The following is a description of a gene set: Mouse Gene Set: GOBP_REGULATION_OF_CALCIUM_ION_IMPORT Any process that modulates the rate, frequency, or extent of the directed movement of calcium ions into a cell or organelle. species: Mus musculus, and this is the list of marker genes: P2rx5, Strit1 (NCBI Gene Id 102637511), Hes1, Eppin, Crh, Ppp3ca, Ppp3cb, Spink1, Slc30a1, Homer1, Prnp, Egf, Gcg, Cav1, Cxcl12, Trim27, Trpv2, Kcnn4, Pdgfb, Atp2c2, P2rx1 (purinergic receptor P2X, ligand-gated ion channel, 1), Isl1, Akap5, Stc1, Ace, Casr, Plpp4, Pdgfrb, Lgals3, Ccl12 (NCBI Gene Id 20293), Grm6, Ms4a1, Dspp, Pln, Wfdc6a, Pawr, Dysf, Serpine1, Cxcr4, Pkd2, Cask, Adrb2, Ppp3cc, Ppp3r2, Trpv3, Cav3, Ppp3r1, Ucn, Agtr1a (NCBI Gene Id 72294), Crhr2, Fyn, Ctnnb1, Adrb1, Wnk3